The following is a description of a gene set: Mouse Gene Set: GOCC_SEMAPHORIN_RECEPTOR_COMPLEX species: Mus musculus A stable binary complex of a semaphorin and a plexin, together forming a functional semaphorin receptor., and this is the list of marker genes: Plxna1, Plxnb1, Plxna3, Plxnb3, Plxna2, Plxna4 (plexin A4), Plxnd1, Sema4d, Erbb2, Plxnb2, Plxnc1